The following is a description of a gene set: The portion of the cytoskeleton contained within the postsynapse. Human Gene Set: GOCC_POSTSYNAPTIC_CYTOSKELETON studied in species Homo sapiens, and this is the list of marker genes: NEFM, ACTN4, NEFH, ITPKA, CTTN, KPTN, ACTB, SPTBN2, ITSN1, MYH10, ACTN2, CTTNBP2, MYO9B, INA, NEFL